Given this list of marker genes OVOL2, CECR2, BMP5, BMP7, HIF1A, LUZP1, CFL1, NODAL, here is a description of the gene set: studied in species Homo sapiens The process in which the neural fold is formed. The edges of the neural plate thicken and move up to form a U-shaped structure called the neural groove. Human Gene Set: GOBP_NEURAL_FOLD_FORMATION